The following is a description of a gene set: The synthesis of fatty acids and cholesterol, the building blocks of membranes, is regulated by three membrane-bound transcription factors: sterol regulatory element-binding proteins (SREBP)-1a, -1c, and -2. Their function in liver has been characterized in transgenic mice that overexpress each SREBP isoform and in mice that lack all three nuclear SREBPs as a result of gene knockout of SREBP cleavage-activating protein (SCAP), a protein required for nuclear localization of SREBPs. Here, we use oligonucleotide arrays hybridized with RNA from livers of three lines of mice (transgenic for SREBP-1a, transgenic for SREBP-2, and knockout for SCAP) to identify genes that are likely to be direct targets of SREBPs in liver. A total of genes showed statistically significant increased expression in livers of transgenic SREBP-1a mice, 505 increased in livers of transgenic SREBP-2 mice, and 343 showed decreased expression in Scap-/- livers. A subset of genes met the stringent combinatorial criteria of induction in both SREBP transgenics and decreased expression in SCAP-deficient mice. Of these genes, 13 were previously identified as direct targets of SREBP action. Of the remaining genes, 13 encode enzymes or carrier proteins involved in cholesterol metabolism, 3 participate in fatty acid metabolism, and 4 have no known connection to lipid metabolism. Through application of stringent combinatorial criteria, the transgenic/knockout approach allows identification of genes whose activities are likely to be controlled directly by one family of transcription factors, in this case the SREBPs. Human Gene Set: HORTON_SREBF_TARGETS species: Mus musculus Genes up-regulated in liver from mice transgenic for SREBF1 or SREBF2 and down-regulated in mice lacking SCAP. from publication Horton JD, Shah NA, Warrington JA, Anderson NN, Park SW, Brown MS, Goldstein JL (PMID 14512514), and this is the list of marker genes: ACLY, HMGCS1, LDLR, FASN, INSIG1, HSD17B7, FDPS, FDFT1, ACACA, RDH11, PMVK, CYP51A1, STARD4, SQLE, PCSK9, ALDOC, LSS, AACS, SC5D, ME1, ELOVL6, IDI1, TM7SF2, ACSS2